The following is a description of a gene set: species: Mus musculus A complex of protein and RNA which facilitates translocation of proteins across membranes. Mouse Gene Set: GOCC_SIGNAL_RECOGNITION_PARTICLE, and this is the list of marker genes: Srp54a, Srp68, Srp72, Srp14, Srp19, Srp54b, Srp54c, Srp9